Given this list of marker genes UCP3, DCLK1, TMED10 (NCBI Gene Id 10972), TNS1, MARCKSL1, SCN2A, PTPRG, FOSB, ANK1, PARP11, MYO3B, UNC45B, ATP7B, FXR1, LPP, NANP, PPME1, TP53INP2, PAXBP1, KLK10, SEPTIN10, GSTM2, BAHCC1, BPTF, USB1, GCSAM, B3GAT1, PIKFYVE (phosphoinositide kinase, FYVE-type zinc finger containing), YIPF3 (Yip1 domain family member 3), CHST9 (carbohydrate sulfotransferase 9), UGT8, XIRP1, ZER1, PAK1, HOXB13, BICRAL, ARFGEF3, PHC2, CDKN1C (cyclin dependent kinase inhibitor 1C), SNX9, ZNF318, ZC4H2, FRYL, PBX2, NDUFA5, KLC2, KHSRP, PROCR, BRPF3, CYP11B1, ZNF106, ATAD5 (ATPase family AAA domain containing 5), GNG13, MAP7D3, EPHB1, NFASC, UNK, TM6SF2, PLXNA4, SHISA2, RPRD1B, TMEM106A, PTGFRN, LCE1A, PKLR, VPS25, ENSG00000255537 (novel transcript, antisense to FEZ1), ELAVL1, GNAO1, ADARB2, PER1, KRT78, GPSM3, ANKRD42, WNT1, GON4L, HNRNPLL, NRIP2, SH2B3, PPP1R8, ATP13A2, NIPBL, KIF3C, FOXL2NB, DIS3, SLC17A8, SMIM21, TMEM104, MPIG6B, TCAF2, AP1G1, PTP4A1, ADCYAP1R1, TMEM245, CIT, C3orf38, MYO19 (myosin XIX), DPF3, CST5, GARIN6, CRY2, MEF2A, RELN, TGM2, INTS5, PBX4, ZFHX3, here is a description of the gene set: Human Gene Set: MIR6778_5P from publication Chen Y, Wang X (PMID 31504780) Genes predicted to be targets of miRBase v22 microRNA hsa-miR-6778-5p in miRDB v6.0 with MirTarget v4 prediction scores > 80 (high confidence targets). studied in species Homo sapiens